Given this list of marker genes FBRSL1, GRIN3A, GFER, RIMS4, SPATA20 (NCBI Gene Id 64847), LMTK3, ZBTB7A, SERTAD2, FAM98C, ZNF385A, MED20, TCF7L2 (NCBI Gene Id 6934), MLLT11, PROSER3, CELF5 (NCBI Gene Id 60680), GNAI2, ANKRD40, TUBB4A, SERTAD4, DYNLRB1, PATZ1, GLT1D1, KLF16, RPS6KL1, IGF2, MYOM3, SHANK1, FXR2, DELE1, NGFR, PPP1R14B, INAVA, FOXJ1, NFIX, SKI, MEAF6, OTOGL, WIZ, FOXE3, CD7, TSC1, MROH5, VAMP2, COL5A3, NFIC, NIPA1, SYNGAP1, CBX6, SALL1, IQSEC2, PLPPR2, FBN3, ARHGDIA, CPNE5 (copine 5), VSTM2L (NCBI Gene Id 128434), KLRD1, SRCIN1, BRSK1, here is a description of the gene set: from publication Chen Y, Wang X (PMID 31504780) Human Gene Set: MIR328_5P studied in species Homo sapiens Genes predicted to be targets of miRBase v22 microRNA hsa-miR-328-5p in miRDB v6.0 with MirTarget v4 prediction scores > 80 (high confidence targets).